The following is a description of a gene set: studied in species Mus musculus Mouse Gene Set: chr16B1, and this is the list of marker genes: Rtp2, Gm4462, Liph, Gm6551, Gm46545, Gm6493, Fetub, Gm24201, Masp1, Camk2n2, 9230117E06Rik, Rtp4, Senp2, AU015336, Tbccd1, 6330408M09Rik, Gng5-ps, Gm4524, Gm22672, Eif4a2, Ahsg, Tmem41a, Gm15651, Gm6557, 4833419O12Rik, Kng2, Sst, Trp63, Fam131a, Gm6640, Gm15746, 1300002E11Rik, Clcn2, Gm18896, Gm22741, Rfc4, Hrg, Chrd, Rps10-ps2, Gm8134 (NCBI Gene Id 666493), Thpo, Tra2b, 2510009E07Rik, Gm20164, Vps8, Kng1, Ephb3, Gm18771, Mir1224, Ndufa11b, Gm9536, Gm5962, Crygs, Mir8095, Gm49514, Gm8130, Gm30251, Gm5809, Gm26980, Dnajb11, Rtp1, Ece2, Gm9697, Vwa5b2, Morf4l1-ps1, Teddm3, Gm16863 (NCBI Gene Id 328646), Gm18769, A230028O05Rik, Magef1, Tprg1, Polr2h (polymerase (RNA) II (DNA directed) polypeptide H), Gm31583, Eef1akmt4, Lpp (LIM domain containing preferred translocation partner in lipoma), Igf2bp2, Eif4g1, Gm30505, Ehhadh, BC106179, Gm8118, Gm18770, Mir6362, Gm46544, Snord2, Gm26744, Mir28a, Gm26447, Gm9525, Gm41434, Gm4521, Alg3, Bcl6, St6gal1, Gm25810 (predicted gene, 25810), Gm24928, Mir7680, Gm27005, Snora81, Eef1ece2, B630019A10Rik, Gm6630, Map3k13, Adipoq, Dgkg, Etv5, Gm24616, Gm24440, Psmd2, Snord66, P3h2, Gm8128, Gm36796